Given this list of marker genes C1S, ERCC3, LMNA, SMAD3, TNFRSF1B, CARMIL2, COL1A2, TERT, WRN, TP53, COL5A1, COL6A2, SPEN, ADAMTS2, CUL4B, BGN, TERC, MMP1, B3GALT6, COL5A2, USB1, KRT14, DKC1, PARN, ATRX, TP63, LOX, PORCN, COL3A1, MGP, BRAF, LAMB3, TGFBR2, CHST14, SMAD2, CTSC, COL1A1, ERCC6, CHD8, GNAS, LAMA3, B4GALT7, TFAP2A, ZMPSTE24, CD28, TGFB3, ARMC5, COL7A1, FERMT1, ACD, ANAPC1, KLHL24, CDH23, LRP1, ERCC2, TGFBR1, CTNNB1, COL6A1, GSN, ERCC5, DSE, CTLA4, FKBP14, CDKN2A, XPA, ABCC6, NR3C1, DST, ENPP1, TGFB2, KRT5, CHD6, DLG4, IPO8, POLD1, COL6A3, PRKAR1A, PLOD1, XPC, SOX18, ZNRF3, ERCC4, COPB1, THBS2, TNXB, LAMC2, ITGB4, RTEL1, AEBP1, COX7B, PDGFRB, TWIST2, COL12A1, NDUFB11, ADA2, HCCS, AIP, PDE11A, PLEC, KDM1A, USP48, FBN1, DHCR24, FBXO11, RECQL4, C1R, DDB2, USP8, TINF2, SLC39A13 (NCBI Gene Id 91252), POLH (NCBI Gene Id 5429), COL17A1, here is a description of the gene set: species: Homo sapiens Partial or complete wasting (atrophy) of the skin. Dermal atrophy Human Gene Set: HP_DERMAL_ATROPHY